The following is a description of a gene set: studied in species Homo sapiens Genes up-regulated in ITGAM+ dendritic cells with IFNAR1 knockout: control versus primary acute viral infection. Murine Cytomegalovirus (MCMV) infection leads to early activation of various immune cells, including B and T lymphocytes, before the actual initiation of antigen-specific adaptive immunity. This activation is partly driven by innate cytokines, including type I interferon (IFN), which are induced early after infection. The objective of this study was to address the role of type I IFN in shaping early/innate B and T cell responses to a primary acute viral infection. In order to decipher the specific impact of IFN-I on cell subsets, we performed a genome-wide expression analysis on WT splenic B and CD8 T lymphocytes isolated from C57BL/6 mixed bone marrow chimera mice. This study complements series GSE39555, which focused on early responses of NK cells and of the two subsets of conventional dendritic cells. Human Gene Set: GSE45365_HEALTHY_VS_MCMV_INFECTION_CD11B_DC_IFNAR_KO_UP, and this is the list of marker genes: APOD, TCOF1, NEIL2, MARCHF9, FOXK1, DSEL, TMEM150A, JADE2, SPOCK2, ZMIZ1, CYB5RL, SGF29 (NCBI Gene Id 112869), USP36, ARHGEF18, ZNF382, EGR2, REG1B, ZIK1, HNRNPU, SAMD12, USP11, PAQR9, RHOBTB2, FAM118A, JHY, MAMDC4, ANXA2P1, MTG1, CCL8, PCNX2, WDR35, SLC35C1 (solute carrier family 35 member C1), CACTIN (NCBI Gene Id 58536), KRI1, SFI1, PHEX, DDX11L2, DSPP, CASS4, SURF2 (surfeit 2), TMEM255A, WIZ, TRMU, ACY1, UNK, ANKS6, PAWR, SCMH1, IL17RE, ZNF85, SH2B1, PORCN, BCL9L, ENPP5, SPOP, PVT1, ZNF175, ZNF444, LTO1, ANKLE1, HESX1 (HESX homeobox 1), KIR2DS5, SURF6 (surfeit 6), STYK1, MATN1-AS1, TUT1, PPIL2, LRRC2, ATF3, HHAT, CELSR1, PHF1, CABIN1, FCMR (Fc mu receptor), ZNF808, OPA3, TTLL5, USP5, PRR12, SOCS1, ZNF827, LTK, GIPC1, PATJ, ANKRD23, JUP (junction plakoglobin), IKZF2, PINX1, PDCD4, USP44, UNC5CL, CHIC1, NSUN4, MSTO1, TELO2, SOX12, UAP1L1, TAF1C, LINC02899, RAMP2-AS1, DNAH12, RPS10P7, XPC, TTC9, TRIM3, DCAF4, PPP1R13B, HPCAL4, RLN2, SLC8A1-AS1, RASSF6, ZNF571, CHD2, REG4, PEG10, AFG2A, COX19, SNPH, PAPOLA, LMF1, MMAB, FAM120C, LANCL3, FLT3LG, MAP3K14, IL23A, NR3C2, KIF5C, NT5E, SARM1, CNN3, ZSWIM9, SLC16A9, SEC14L1P1, FAM24B, ANKEF1, POFUT1, C10orf95-AS1, CNNM3, ANK3, NAT9, POMGNT1, TYSND1, FAM53B, AMDHD1, EPB41L4A, KLF8, NFATC3, ZNF542P, ARRDC2, TMEM14B, LRRN3, GRAMD1C, TTC39B, SOBP, FN1, RHD, ZNF329, SF3B2, RPAP1 (RNA polymerase II associated protein 1), TPPP3, DISP1, EXD2, TSPAN7, ZNF286A, NOSIP, PDE4DIP, CAPN15, LETM1, YJU2 (YJU2 splicing factor homolog), YDJC, EIF3B, MEF2D (NCBI Gene Id 4209), EPHB6, NOP2, RCN3 (reticulocalbin 3), IMMP2L, ZNF91, CNTNAP2, CLPX, MYEF2, NF2, ALKBH5, EBLN3P, ENAM, KHDC3L, HCFC1, DCK, LILRA4, TGIF1, ZSCAN12, ZNF204P, ZNF331, CA6